The following is a description of a gene set: studied in species Mus musculus This event has been computationally inferred from an event that has been demonstrated in another species.<p>The inference is based on the homology mapping from PANTHER. Briefly, reactions for which all involved PhysicalEntities (in input, output and catalyst) have a mapped orthologue/paralogue (for complexes at least 75% of components must have a mapping) are inferred to the other species. part of: Asparagine N-linked glycosylation electronically inferred by orthology from the curated human pathway Reactome Pathway: Biosynthesis of the N-glycan precursor (dolichol lipid-linked oligosaccharide, LLO) and transfer to a nascent protein, and this is the list of marker genes: St6galnac3, St6galnac1, Amdhd2, Neu1, St8sia3, Gfus, St8sia4, Npl, Nudt14, Gmppb, Alg12, Neu2, Slc35c1, Gmppa, St6gal2, St6galnac2, Fpgt, St8sia5, St8sia2, Nagk, Cmas, Alg1, St3gal2, Gnpnat1, Nans (NCBI Gene Id 94181), St3gal4, Glt28d2, Alg8, St6galnac6 (ST6 (alpha-N-acetyl-neuraminyl-2,3-beta-galactosyl-1,3)-N-acetylgalactosaminide alpha-2,6-sialyltransferase 6), Fuom, Dolk, Renbp, St3gal3, Neu4, Neu3, Nanp, Gfpt2, St3gal5, Alg6, St6galnac4